Given this list of marker genes ABCC4, ABCC1, SLC13A3, ABCC5, GJA1, SLC15A2, NHERF1, SLC25A40, SLC25A39, SLC7A11, MGST1, SLC15A1, here is a description of the gene set: Human Gene Set: GOBP_TRIPEPTIDE_TRANSPORT The directed movement of a tripeptide, a compound containing three amino acids linked together by peptide bonds, into, out of or within a cell, or between cells, by means of some agent such as a transporter or pore. species: Homo sapiens